The following is a description of a gene set: from publication Chen Y, Wang X (PMID 31504780) Mouse Gene Set: MIR_12181_5P studied in species Mus musculus Genes predicted to be targets of miRBase v22 microRNA mmu_miR_12181_5p in miRDB v6.0 with MirTarget v4 prediction scores > 80 (high confidence targets)., and this is the list of marker genes: Myadm, Tmem41a, Zfp91, Odaph, Zfp114 (NCBI Gene Id 545533), Zfp987 (zinc finger protein 987), Tm4sf20, C030006K11Rik, Pirt, Ly86, Plagl1, S100a14, Fgf5, Mbnl3, Trpm3, Dspp, Wnt2b, Arid1b, Cnot9, Arhgap18, Wdr48, Camk1g, Hs2st1, Prss8, Sumo1, Fam181b (NCBI Gene Id 58238), E2f4, Creb1 (NCBI Gene Id 98624), Tsfm, Lrtm1, S100a10, Chmp7, Zfp994, Ep300, Morc2a